Given this list of marker genes CHMP2B, RAB27A, RUFY4, CHMP4B, TMEM50A, LAPTM4B, VPS37B, LEPROT, MVB12B, VPS25, DENND10, VPS36, VPS37D, CHMP7, LYST (lysosomal trafficking regulator), RILP, VPS4A, SYTL4, TMEM50B, VPS37A, STAM, UVRAG, VPS28, SNF8, EXPH5, RAB27B, STAM2, CHMP3, CHMP5, PTPN23, VCP, CHMP6, SORT1, TSG101, HGS, VPS4B, VPS37C (NCBI Gene Id 55048), MVB12A, MITD1, CHMP4C, CHMP1A, CHMP4BP1, LEPROTL1, UBXN6, CHMP2A, RUBCN, CHMP4A, VTA1, UBAP1, CHMP1B, here is a description of the gene set: species: Homo sapiens A vesicle-mediated transport process in which transmembrane proteins are ubiquitylated to facilitate their entry into luminal vesicles of multivesicular bodies (MVBs); upon subsequent fusion of MVBs with lysosomes or vacuoles, the cargo proteins are degraded. Human Gene Set: GOBP_MULTIVESICULAR_BODY_SORTING_PATHWAY